Given this list of marker genes Fgf8, Fgf3, Bmp2, Spry1, Hoxc11, Robo1, Mesp1, Fgf10, Wnt2, Ctnnb1, Bmp4, Six1, Gdnf, Gata5, Fgf1, Frs2, Hoxa11, Dkk1, Fgf2, Wnt2b, Ar, Fgfr4, Hoxd11, Rbpj, Robo2, Fgfr1, here is a description of the gene set: The interaction of two or more cells or tissues that causes them to change their fates and specify the development of an organ. studied in species Mus musculus Mouse Gene Set: GOBP_ORGAN_INDUCTION